Given this list of marker genes MEST, TFRC, TARBP1, AK4, HSPE1, MRPL3, FKBP4, BOP1, ABCE1, RPIA, PEBP1, EXOSC7, EXOSC2, RABEPK, SRPK1, SLC39A14, RRS1, PYCR1, CTPS1, UCHL3, RCC1, SLC39A6, MXI1, TRAP1, VARS1, PUM3, NAMPT, ACSL1, IARS1, FABP5, MTHFD1, SRM, FASN, AHCY, DANCR, RANBP1, CAD, DHODH, CYCS, POLR2H, ATP1B3, NOLC1, PNO1, SLC20A1, SORD, DDX21, CEBPZ, EBNA1BP2, CTSC, AUH, UCK2, PPAT, GRSF1, TMEM97, GPD1L (glycerol-3-phosphate dehydrogenase 1 like), TBL3, ZNF239, LRP8, MGST1, PRPS2 (phosphoribosyl pyrophosphate synthetase 2), IMPDH2, NME1, DCUN1D4, FXN, RRP1B, NEFH, SLC16A1, PAICS, POLD2, LDHA, MYC, CYP51A1, GCSH, DDX10, ODC1, CDK4, AKAP1, AIMP2, VRK1, PRDX4, here is a description of the gene set: The proto-oncogene c-myc (myc) encodes a transcription factor (Myc) that promotes growth, proliferation and apoptosis. Myc has been suggested to induce these effects by induction/repression of downstream genes. Here we report the identification of potential Myc target genes in a human B cell line that grows and proliferates depending on conditional myc expression. Oligonucleotide microarrays were applied to identify downstream genes of Myc at the level of cytoplasmic mRNA. In addition, we identified potential Myc target genes in nuclear run-on experiments by changes in their transcription rate. The identified genes belong to gene classes whose products are involved in amino acid/protein synthesis, lipid metabolism, protein turnover/folding, nucleotide/DNA synthesis, transport, nucleolus function/RNA binding, transcription and splicing, oxidative stress and signal transduction. The identified targets support our current view that myc acts as a master gene for growth control and increases transcription of a large variety of genes. from publication Schuhmacher M, Kohlhuber F, Hölzel M, Kaiser C, Burtscher H, Jarsch M, Bornkamm GW, Laux G, Polack A, Weidle UH, Eick D (PMID 11139609) studied in species Homo sapiens Human Gene Set: SCHUHMACHER_MYC_TARGETS_UP Genes up-regulated in P493-6 cells (Burkitt's lymphoma) induced to express MYC.